Given this list of marker genes SMC2, SEC13, NCAPD3, RANBP2 (RAN binding protein 2), H2BC11, H3-4, H2AC14, NUP205, NUP155, H3C12 (H3 clustered histone 12), MCPH1, NUP98, CDK1, H2AZ2, POM121, H4C12, NUP93, NUP35, H4C5, NUP107, NUMA1, H4C13, H4C3, ENSA, SMC4, USO1, NCAPG2, H2BC15, H3C14, H4C1, RAB2A, GORASP1, CCNB1, NUP160, H2AC8, H2AC7, VRK2, NEK7, H2AC20, H2AC19, LMNA, PPP2R1A, BANF1, GORASP2 (NCBI Gene Id 26003), KMT5A, NDC1, LEMD2, NUP88, GOLGA2, H2AC18, H3-3A, H2BC6, H2AX, H2AJ (NCBI Gene Id 83739), H3C4, LEMD3, PPP2R1B, SEH1L, NUP188, H3-3B, NEK6, CNEP1R1, H2BC4, H2BC26 (H2B clustered histone 26), LPIN3 (lipin 3, NCBI Gene Id 64900), H4C8 (H4 clustered histone 8), BLZF1, H3C1, LPIN2, MAPK1, POM121C, NUP214, H3C13, LMNB1, H4C2, EMD, H4C15, H3C8, PPP2R2D (protein phosphatase 2 regulatory subunit Bdelta), NUP37, H2BC10, H2BC17, H2BC9, H3C6, H2BC21, H4C9, PRKCB, PPP2CA, H2BC14, CTDNEP1, NUP58, NCAPH2, H2BC12, H3C7, H4C11, NUP43, H2BC3, RAE1, TPR, H3C3, NUP54, H4C6, H3C11, H2BC7, H4C4, TMPO, RAB1B, CCNB2, NUP42, LPIN1, H2BC8 (NCBI Gene Id 8339), H4C16, H4C14, H3C2, NUP50, NUP133, SET, H3C15, NUP62, H3C10, H2BC13, H2AC6, MASTL, H2BC5 (NCBI Gene Id 3017), NEK9, NUP153, MAPK3, AAAS, PRKCA, NUP85, H2BC1, PPP2CB, VRK1, RB1, PHF8, H2BC12L, H2AC4 (H2A clustered histone 4), PLK1, RAB1A, ARPP19, NUP210, H2AB1, here is a description of the gene set: Mitotic Prophase Human Gene Set: REACTOME_MITOTIC_PROPHASE species: Homo sapiens